Given this list of marker genes SIRT6, SIRT1, SUDS3, SIRT4, MAPK8, MIER1, HDAC4, HDAC6, HDAC11, HOPX, HDAC8, HDAC3, MIER2, SKI, TP53, UCN, SIRT2, HDAC9, MIER3, MTA2, HDAC5, HDAC2, SIRT5, HDAC1, ING2 (inhibitor of growth family member 2), HDAC7 (NCBI Gene Id 51564), SIRT7, HDAC10, SIRT3, here is a description of the gene set: Catalysis of the reaction: Removal of an acetyl group from a lysine residue in a protein. Human Gene Set: GOMF_PROTEIN_LYSINE_DEACETYLASE_ACTIVITY studied in species Homo sapiens